Given this list of marker genes IFNB1 (interferon beta 1), SMAD7, IFNA2, ARG1, XCL1, LILRB4, HFE, SLAMF1, FOXP3, HLA-F, TBX21, here is a description of the gene set: species: Homo sapiens Any process that stops, prevents, or reduces the frequency, rate, or extent of T cell cytokine production. Human Gene Set: GOBP_NEGATIVE_REGULATION_OF_T_CELL_CYTOKINE_PRODUCTION